The following is a description of a gene set: The aggregation, arrangement and bonding together of a proton-transporting ATP synthase in the mitochondrial inner membrane. studied in species Mus musculus Mouse Gene Set: GOBP_MITOCHONDRIAL_PROTON_TRANSPORTING_ATP_SYNTHASE_COMPLEX_ASSEMBLY, and this is the list of marker genes: Atp23, Atpaf2, Oxa1l, Fmc1, Atp5f1d, Tmem242, Tmem70, Atpaf1 (NCBI Gene Id 98399)